Given this list of marker genes Gsdmc, Znrf2 (zinc and ring finger 2), Fam199x, Slc16a9, Knstrn, Aldh1b1, Uevld, Ldc1, Zfp91, Phrf1, Orc3, Tead1, Prpf39 (pre-mRNA processing factor 39), Or51m1, Ppp4r3c2, Sgo2a, Gdap2, Papola, Iqck, Barhl1, Vhl, Dennd2c, Eif5a2, Aqr, Gtf3c4 (NCBI Gene Id 99180), Plscr2, Rfx6, Neurog2, Igf1, Or52n4, Vcan, Trhr, Kpna3, Ccr4, Nsun6, Dsc3, Lrrc75b, Ccdc80, Slc6a1, Slc2a13, Bmpr2, Chst2, Epm2aip1, Shisal2b, Sval1, Cyp2j5, Col4a2, Pik3r1, Atp13a5, Atg12, Rbm39, Lman1, Ggt6, Rora, Nek5, Onecut2, Rbms1 (RNA binding motif, single stranded interacting protein 1), Wapl, Ppp4r2, Tmbim7, Slc24a2, Reg1, Cd164, Stpg2, Zim1, Nkapd1, Dnajb4, Ehmt1, Slc39a6, Lactb2, Syap1, Fli1, Stxbp5l, Sox5, Vwa5a, Sash1, Mdga2 (MAM domain containing glycosylphosphatidylinositol anchor 2), Agfg1, Eif4g2, Rpgrip1l, here is a description of the gene set: from publication Chen Y, Wang X (PMID 31504780) Genes predicted to be targets of miRBase v22 microRNA mmu_miR_5116 in miRDB v6.0 with MirTarget v4 prediction scores > 80 (high confidence targets). studied in species Mus musculus Mouse Gene Set: MIR_5116